Given this list of marker genes Cyp26b1, Adh1, Dhrs9, Rdh13, Dhrs4, Akr1c20, Rdh5, Aldh1a2, Rdh14, Rdh10, Akr1c6, Cyp26c1, Adh4, Sdr16c5, Rdh11, Aldh8a1, Akr1c21, Aldh1a1, Dhrs3, Cyp26a1, Rdh1, Aldh1a3, Crabp1, here is a description of the gene set: RA biosynthesis pathway studied in species Mus musculus Mouse Gene Set: REACTOME_RA_BIOSYNTHESIS_PATHWAY